Given this list of marker genes STATH, HACD1, AMELX, BGLAP, CEMP1, here is a description of the gene set: Binding to hydroxyapatite, the calcium phosphate mineral of formula Ca10(PO4)6(OH)2 found both in rocks of nonorganic origin and as a component of bone and dentin. Human Gene Set: GOMF_HYDROXYAPATITE_BINDING species: Homo sapiens